Given this list of marker genes P2rx7, Oxt, Myb, Fzd4, Nos2, Igfbp3, Cyp19a1, Map2k6, Pla2g3, Crhr1, Gdf9, Ren1, C1qtnf1, Atp5pf, Pla2g4a, Crh, Inhba, Agtr2, Lep, Nkx3-1, Galr1, Gal, Selenom, Pomc (NCBI Gene Id 18976), Nucb2, Spp1, Runx1, Dab2 (disabled 2, mitogen-responsive phosphoprotein), Cry1, Surf4, Tspo, Sar1b, Ptpn11, Mfn2, Il1b, Tmf1, Tnfsf11, Nrg1, Ecrg4, Edn1, Abcc4 (ATP-binding cassette, sub-family C member 4), Pla2g10, Agt, P2ry2, Mif, Cry2, Ptges, Kdm5b, Kcnk9, Agtr1a, Bmp6 (NCBI Gene Id 28108), Kcnq1 (potassium voltage-gated channel, subfamily Q, member 1), Tnfrsf11a, Wnk4, Ghrl, Ptgs2, Cyp2j5, Retn, Mapk9, Nmb, Tac1, Acsl4, Il1a, here is a description of the gene set: studied in species Mus musculus The directed movement of a lipid from a cell, into the extracellular region. Mouse Gene Set: GOBP_LIPID_EXPORT_FROM_CELL